Given this list of marker genes Htr7, Cd38, Agt, Edn2, Edn3, Scnn1b, Dock4, Edn1, Slc8a1, Rap1gds1, Atp2b1, Comp, Ednra, Smpd3, Rhoa (ras homolog family member A), Cacna1g, Dock5, Chrm3, Arhgap42, Mkks, Zdhhc21, Ednrb, Bbs2, Htr2a, Grip2, Adra2b (adrenergic receptor, alpha 2b), Map2k1, P2rx1, Stub1 (STIP1 homology and U-Box containing protein 1), Acta2, here is a description of the gene set: species: Mus musculus A process, occurring in the vascular tissue, whereby actin/myosin complex activity generates force through ATP hydrolysis resulting in a change in smooth muscle geometry. This process is always coupled to chemo-mechanical energy conversion. Mouse Gene Set: GOBP_VASCULAR_ASSOCIATED_SMOOTH_MUSCLE_CONTRACTION